The following is a description of a gene set: The activation of muscle-specific gene expression requires the coordinated action of muscle regulatory proteins and chromatin-remodeling enzymes. Microarray analysis performed in the presence or absence of a dominant-negative BRG1 ATPase demonstrated that approximately one-third of MyoD-induced genes were highly dependent on SWI/SNF enzymes. To understand the mechanism of activation, we performed chromatin immunoprecipitations analyzing the myogenin promoter. We found that H4 hyperacetylation preceded Brg1 binding in a MyoD-dependent manner but that MyoD binding occurred subsequent to H4 modification and Brg1 interaction. In the absence of functional SWI/SNF enzymes, muscle regulatory proteins did not bind to the myogenin promoter, thereby providing evidence for SWI/SNF-dependent activator binding. We observed that the homeodomain factor Pbx1, which cooperates with MyoD to stimulate myogenin expression, is constitutively bound to the myogenin promoter in a SWI/SNF-independent manner, suggesting a two-step mechanism in which MyoD initially interacts indirectly with the myogenin promoter and attracts chromatin-remodeling enzymes, which then facilitate direct binding by MyoD and other regulatory proteins. Genes up-regulated in NIH 3T3 cells (fibroblasts) 24 h after inducing MYOD which were down-regulated by dominant negative form of SMARCA4. from publication de la Serna IL, Ohkawa Y, Berkes CA, Bergstrom DA, Dacwag CS, Tapscott SJ, Imbalzano AN (PMID 15870273) Mouse Gene Set: DELASERNA_TARGETS_OF_MYOD_AND_SMARCA4 studied in species Mus musculus, and this is the list of marker genes: Myog, Tnnt2, Acta1, Myh3, Myl4, Igfbp5, Bin1, Tnnc2, Tnnt3, Tnni2, Mylpf